The following is a description of a gene set: Human Gene Set: HP_IMPAIRED_COLLAGEN_INDUCED_PLATELET_AGGREGATION Abnormal response to collagen or collagen-mimetics as manifested by reduced or lacking aggregation of platelets upon addition collagen or collagen-mimetics. Impaired collagen-induced platelet aggregation studied in species Homo sapiens, and this is the list of marker genes: BLOC1S5, HPS6, CALR, CISD2, ITGA2B, EPHB2, LCP2, TPM4, THPO, RUNX1, GP6, ITGB3, IKZF5, NBEAL2, SH2B3, GFI1B